Given this list of marker genes SCAF8, MEIS2, POU3F2, PLEK, ZNF511, LHFPL6, C18orf63, OLFML3, TLK1, HAS2, ZC4H2, NIPA1, ZNF728, NF1, SMARCC2, SH3GL1, AMOTL2, FANCD2, ANP32E, LCORL, CYRIB, FAAP20, FAM86C1P, GABRG1, EREG, MICOS10, NSD1, KIF4A, ABRA, ZNF630, SPTBN1, C2CD4C, MIDEAS, NID1, H2BC12 (NCBI Gene Id 85236), TRIM66, ZNF609, RREB1, UBA6, ABHD3, ZNF20, PRKAR2A, JAG2, ENSA, CACNA2D1, AMIGO2, SHROOM4, PEA15, IRS1, WFIKKN2, ADAR, ZNF493, CC2D1B, MRPL19, DERL2, NELL2, SMARCC1, HSPA13, TRPS1, RNF38, CERS5, ZCCHC10, LRP1B, ARHGAP32, GNA12, COQ4, KRTAP4-3, DEPP1, IPO11, CLYBL, FOXK2, CPM, SETDB1, CFAP58, ZNF676, RTL5, VDAC3, MAPK1, CPEB1, HAP1, ZNF260, HDAC6, LARP7, DNALI1, AADACL3, KLF12, CBLL2, CDK17, ZNF257, DLC1, CSNK2A1, CDCA2, METTL8, SERTAD2, SH3BP4, INSR, TFAP2B, AMD1, FAM86B1, GSTM5, FBXO5, LUM, here is a description of the gene set: Genes predicted to be targets of miRBase v22 microRNA hsa-miR-3928-3p in miRDB v6.0 with MirTarget v4 prediction scores > 80 (high confidence targets). Human Gene Set: MIR3928_3P species: Homo sapiens from publication Chen Y, Wang X (PMID 31504780)